The following is a description of a gene set: Vertical bony ridge positioned in the midline of the forehead. studied in species Homo sapiens Prominent metopic ridge Human Gene Set: HP_PROMINENT_METOPIC_RIDGE, and this is the list of marker genes: PDX1, TWIST1, SRCAP, KCNQ1, FOXG1, INS, CDC6, MEGF8, NSRP1, SC5D, ADAMTSL1, ALG9, IGF2, ACTG1, MAP1B, KCNJ11, HNRNPK, SLC4A10, ADSL, PURA, KANSL1, ACTB (actin beta), EBF3, ASXL1, NAA10, HNRNPU, RAB23, ABCC8, ZNF462, GJA5, IFT140, ADARB1, H3-3B, ERCC2, ERMARD, MID1, CDKN1C, ERCC1, KDM4B, LMX1B, ZNF292, GCK, TBCK, ATIC, CRELD1, KCNQ1OT1, RTTN, STXBP1, INTU (inturned planar cell polarity protein), IL11RA, ERCC5, NOTCH3, SMARCD1, KDM5B, CLCN3, SMG9, GNPTAB, TOGARAM1, NUP188, CAMSAP1, GJA8, NARS2, MAPK1, RNU4-2, ERCC6, PPP2R1A, STAT3, MAF, FBXL4, RNU4ATAC